The following is a description of a gene set: Genes up-regulated in neural progenitor cells (NPC) isolated from E13 cortical tissue of SMRT knockout mice. Mouse Gene Set: JEPSEN_SMRT_TARGETS from publication Jepsen K, Solum D, Zhou T, McEvilly RJ, Kim HJ, Glass CK, Hermanson O, Rosenfeld MG (PMID 17928865) A series of transcription factors critical for maintenance of the neural stem cell state have been identified, but the role of functionally important corepressors in maintenance of the neural stem cell state and early neurogenesis remains unclear. Previous studies have characterized the expression of both SMRT (also known as NCoR2, nuclear receptor co-repressor 2) and NCoR in a variety of developmental systems; however, the specific role of the SMRT corepressor in neurogenesis is still to be determined. Here we report a critical role for SMRT in forebrain development and in maintenance of the neural stem cell state. Analysis of a series of markers in SMRT-gene-deleted mice revealed the functional requirement of SMRT in the actions of both retinoic-acid-dependent and Notch-dependent forebrain development. In isolated cortical progenitor cells, SMRT was critical for preventing retinoic-acid-receptor-dependent induction of differentiation along a neuronal pathway in the absence of any ligand. Our data reveal that SMRT represses expression of the jumonji-domain containing gene JMJD3, a direct retinoic-acid-receptor target that functions as a histone H3 trimethyl K27 demethylase and which is capable of activating specific components of the neurogenic program. studied in species Mus musculus, and this is the list of marker genes: Nif3l1, Apoe, Ppp1r1a, Elavl3, Dscam, Rbp1, Spry4, Hmga1, Hmox1, Zbtb5, Arl8b, Timp1, Lims2, Adat2, Igf2r, Mga, Ntng1, Srxn1, Abca1, Pdgfa (NCBI Gene Id 18590), Tcf25, Egr1, Tnfrsf12a, Metrn, Syt12, Sparc, Zfp472, Dcx, Cgref1, Pdlim4, Zfp449 (NCBI Gene Id 78619), Esd, Kdm6b, Prdm15